The following is a description of a gene set: Expression profiling of Rag2-deficient Ets1++ and Rag2-deficient Ets1-- mature NK cells and WT bone marrow progenitors, WT T cells, and WT Pro B cells Genes down-regulated in hematopoietic stem cells versus common lymphoid progenitors. from publication Ramirez K, Chandler KJ, Spaulding C, Zandi S, Sigvardsson M, Graves BJ, Kee BL (PMID 22608498) studied in species Homo sapiens Human Gene Set: GSE37301_HEMATOPOIETIC_STEM_CELL_VS_COMMON_LYMPHOID_PROGENITOR_DN, and this is the list of marker genes: LHX1 (LIM homeobox 1), PRDX4, SLCO5A1, PDCD1LG2, ACAD8, NIN, LIF (NCBI Gene Id 3976), ARMC6, ZKSCAN5 (NCBI Gene Id 23660), DNTTIP2, FOXJ3, GRIN2C, CXCL10, ELN, B3GALT5, UQCRC2, EXOC2, ASIC1, RUVBL1, RAB40B, NRIP1, TREM2, CIAO1, RBBP8, MPIG6B, DR1, ATP5PB, RABGGTA, NELL2, THBS2, MID1IP1, LSM2, ETFB, KCNK13, NGRN, C8A, MMP10, GCG, RHEB, MAD1L1, FCGR2B (NCBI Gene Id 2213), MCM3, C5orf15, XRCC5, LMOD1, RAD1, SNRPA1, PRG2, ARMC1, CHRNA6, POU4F3, ZNF571, SNCG, CLPB, GRID2, SLC22A8, THAP4, CLK4, SACS, RRH, PLXNB2, ADPRH, GNAI1, KLF3-AS1, VPS54, GRM3, SPTLC1, GPR65, SPINT2, RBL2 (NCBI Gene Id 5934), ODAM, DYSF, LY96, JAG1, CEP112, F2RL2, TPP2, MEGF6, NUP205, LCN1, HEXA, AGK (acylglycerol kinase), MCTS1 (NCBI Gene Id 28985), EDC3, LEF1, GABRA3, ZNF682, NUCB2, RPUSD2, ACTR3B, POLR2D (RNA polymerase II subunit D), HSPE1, RIN2, CAPZA2, HIVEP1, MYH13, SMARCA5, HIGD1B, KHDRBS1, CXCR2, EPHX1 (NCBI Gene Id 2052), ZBED4, MGLL, LDLRAD4, EIF3F, GSTA4, ELMO1, C1S, FDX1, NOP53, SPI1, CORO2A, PJA2, GIT2, ABLIM1, FAM131B, ATP6V1B2, ECE2, RAP1GAP2 (NCBI Gene Id 388321), STXBP3, MTMR6, RPAP3, DAP3, COMMD9, RPH3A, NCBP1, TMEM70, INHBA, KLHL29, UBXN8 (NCBI Gene Id 7993), ZNF23, HMHB1, CFH, YTHDC2, TMF1, GLOD4, STAT3, SH3YL1, PCK2, TUT1, MGST2, EIF4EBP1, POLD3, MAPK6, LRRC8D, HDAC2, VENTX, H2AZ2, FSTL3, PLA2G2F (NCBI Gene Id 64600), SLC2A4, FLT3, SQLE, SINHCAF, ANKZF1, PTGIR, BIRC3 (NCBI Gene Id 330), TMEM127 (NCBI Gene Id 84178), CHN2, PUF60, STK38L (NCBI Gene Id 23012), CNIH4, ACP3, PRKACB, MAP2K6, SUCLG2, IKZF2, YBX2, ITM2C, SLC25A5, CASP4, SLC47A1, PTPRT, SCAI, CUTC, IL7R, STARD7, CCDC177, INPP5A (inositol polyphosphate-5-phosphatase A), VASH2, SLC19A4P, DBF4, ZNF334, ATP6V0E1, CEP170, GJA1, EPRS1, RHOH, IL9, NT5C, XPO4, IPP, SNRPD2 (NCBI Gene Id 6633), C11orf58, UQCR11, ZNF652, COX7C (NCBI Gene Id 1350), INSM1, CUL3, PEPD